The following is a description of a gene set: Regulatory T (Treg) cells that express the FoxP3 transcription factor are essential for lymphoid homeostasis and immune tolerance to self. Other non-immunological functions of Treg cells, such as controlling metabolic function in adipose tissue, are also emerging. Treg cells originate primarily in the thymus, but can also be elicited from conventional T cells by in vivo exposure to low-dose antigen or homeostatic expansion, or by activation in the presence of TGFβ in vitro. Treg cells are characterized by a distinct transcriptional signature controlled in part, but not solely, by FoxP3. For a better perspective on transcriptional control in Treg cells, we compared gene expression profiles of a broad panel of Treg cells from various origins or anatomical locations. Treg cells generated by different means form different sub-phenotypes identifiable by particular combinations of transcripts, none of which fully encompass the entire Treg signature. Molecules involved in Treg effector function, chemokine receptors, and the transcription factors that control them are differentially represented in these subphenotypes. Treg cells from the gut proved dissimilar to cells elicited by exposure to TGFβ, but instead they resembled a CD103+Klrg1+ subphenotype preferentially generated in response to lymphopenia. Genes up-regulated in comparison of TregCD103-Klrg1- versus TregCD103+Klrg1- (see Table 1S in the paper for details). from publication Feuerer M, Hill JA, Kretschmer K, von Boehmer H, Mathis D, Benoist C (PMID 20231436) Human Gene Set: GSE20366_CD103_POS_VS_NEG_TREG_KLRG1NEG_UP studied in species Homo sapiens, and this is the list of marker genes: ACSF3, NRL, JMJD6, BTF3 (basic transcription factor 3), CLASP2, ROR2, TMEM64, FOXP1, PDGFRA, PLEKHJ1, CASP12, GNAS-AS1, ADAMTS2 (NCBI Gene Id 9509), ZNF493, TIGD3, CLRN3, MMP24, SGTB, SERPINH1, ZBTB8B, ARMH3, SMG5, WNT3, SMAGP, NAPB, KCNJ9, PITPNC1, CCL13 (C-C motif chemokine ligand 13), PMFBP1, LGALS3, CSNK1E, CCDC33 (NCBI Gene Id 80125), TMEM63B, MAPK12, SEMA7A, KCNH7, LDOC1, TMEM216, KLK12, GABRA5, CORT, AP5Z1, BRWD1, UGT2B4, WDR62, TRIM31, ADAM7, ETS2, GP6, PTPRF (protein tyrosine phosphatase receptor type F), HSD17B2, NTSR1, GAST, SCG5, AMIGO2, TMC1, TICRR, C2CD4B (NCBI Gene Id 388125), ITPKA, ACSL6, PHACTR1, DNAJC6, ARHGEF10, COL25A1, GPNMB, DUS2, SOX15, NKX2-4, LPCAT4, DAND5, SPMIP5, LMAN1L, TTL, AGER, ZNF397, GCSAM, ZNF474, SCARF1, THEMIS, ARMC3, GNRHR (gonadotropin releasing hormone receptor), SLC16A9, TUBB2B, MATCAP2, TXNDC2, OPN1LW, NDUFA4L2, CPLANE2, DKK2, CCDC102A, ZFP37, KCNG2, TEX47, MX1, PNPLA1, COL5A2, CD9, NLRP9, RSPO2, DPH1, PRCD, WWTR1 (NCBI Gene Id 25937), GFM2, BCL11A, UPK1A, CYLC2, BRD10, SPRED3, WHAMM, EVL, MARS2, HOXD9, DIO1, ALS2CL, PTPN14, TCEA2, CELSR1, CYB5R2, ZMAT5, TPH2, SURF2, PF4, CTSV, ADAMTSL3, SLC1A6, DUSP23, SHB, MCAM, ANKS4B, EYA4, SPACA7, SPECC1, ARK2C, TSPAN7, EPAS1, NRK, AIF1L, CPNE9, POLG2, SPRY4, PIK3AP1, KCNK12, INMT, RALGPS2, IGFBP4, SH3YL1, LPO, FAM170A, PRM2, ATP11A, CCL19, JADE3, LHFPL6, RPTOR, ATXN7L2, PTCRA, ZMYND10, ITGA2B, CCDC81, OSM, ZNRF4, OVOL2, TM6SF2, IL12A, SNX32, ARL13A, SGK3, PLEKHG6, C1QA, GPR179, TAF6L, COTL1, YAE1 (YAE1 maturation factor of ABCE1), SOX14, CCDC80, TMCO3, BRS3, AACS, TIMP1, DLGAP3, SLC25A42, OBP2B, GPD1, LRRC38, NACC1, BRME1, ADCY6, GADD45GIP1, POM121L2, HP, CC2D2B, PIP4K2A, DKK1, GPR63, LSM7, MNT, LRMDA, EME1, BBS5 (Bardet-Biedl syndrome 5), FHOD3